The following is a description of a gene set: Human Gene Set: RAMPON_ENRICHED_LEARNING_ENVIRONMENT_LATE_UP An enriched environment is known to promote structural changes in the brain and to enhance learning and memory performance in rodents. To better understand the molecular mechanisms underlying these experience-dependent cognitive changes, we have used high-density oligonucleotide microarrays to analyze gene expression in the brain. Expression of a large number of genes changes in response to enrichment training, many of which can be linked to neuronal structure, synaptic plasticity, and transmission. A number of these genes may play important roles in modulating learning and memory capacity. from publication Rampon C, Jiang CH, Dong H, Tang YP, Lockhart DJ, Schultz PG, Tsien JZ, Hu Y (PMID 11070096) studied in species Mus musculus Genes up-regulated in the brain cortex of mice that were exposed to an enriched learning environment for 2 or 14 days., and this is the list of marker genes: CORO1A, USP21, DLG4, POLR2C, XBP1, CTTN, DNPEP, DCTN5, CALB2, PSMB3, TBCA, SEZ6, CDH2, CLPP, XPNPEP1, ZIC1, MAP4, CALM3, VLDLR, BTF3, DHX32